The following is a description of a gene set: species: Mus musculus Binding to the small ubiquitin-like protein SUMO. Mouse Gene Set: GOMF_SUMO_BINDING, and this is the list of marker genes: Simc1, Pml, Tollip, Pelp1, Uspl1, Serbp1, Habp4, Zcchc12, Uba2, Sobp, Herc2, Tdg-ps, Rnf111, Tdg, Rnf4, Casp8ap2, Cbx4, Usp25